The following is a description of a gene set: Mouse Gene Set: MIR_215_3P Genes predicted to be targets of miRBase v22 microRNA mmu_miR_215_3p in miRDB v6.0 with MirTarget v4 prediction scores > 80 (high confidence targets). studied in species Mus musculus from publication Chen Y, Wang X (PMID 31504780), and this is the list of marker genes: Map3k20, Tbl1xr1, Nsun5, Coro2b, Eif4enif1, Zfp689, Tmem45a2, Cxcl12, Ttc7b, Ikzf2, Slc9a2, Sdhd, Fdx1, Ccdc122, Hira, Srsf1, Ppig, Tnrc6b (trinucleotide repeat containing 6b), Slit2, Gna12, Ppargc1a, Rasl12, Slc26a3, Klhl4, Efcab5, Xk, Rundc3a, Sim1, Rgmb, Hdac9 (histone deacetylase 9), Tnn, C1galt1c1 (NCBI Gene Id 97604), Scai, Eif1a, Ankrd66, Ophn1, Ntrk2, Dcun1d1, Grid1, Clk2, Tead1, Ereg, Cul2, Sgcd, Rab38, Tenm3, Fli1 (Friend leukemia integration 1), Ftsj1, Spopfm2, Rfx3, Tmem45a, Tfrc, Ppp1r2, Htr4, Hsf3, Zmat2, Sfmbt1, Timm8b, Tmem65, Gpm6b, Hp1bp3, Tmem168, Pramel1 (PRAME like 1), Itgbl1, Eif4h, Ccin, Nrarp, Avl9, Yaf2, Nans, Lratd1, Nfib, Igsf11, Dmd, Zc3h14, Sertad2, Becn1, Sec23ip, Sulf1, Wwp1, Fbxo30, Spock3, Baz1b (bromodomain adjacent to zinc finger domain, 1B), 6030458C11Rik, Radil, Togaram1, Kcnh8, Atp2a1, Gpcpd1, Dnajb5, Trub1, Zfand4, Tom1l1, Lrtm1, Dclk1, Gdi2, Fam168a, Pcdh9, Pafah2, Cysltr1 (cysteinyl leukotriene receptor 1), Uty, Tbcel, Chsy3, Cnot6l, Gli2, Frrs1l, Dgkb, Meox2, Strn, Ckmt2, Sumf1, Zfp110, Usp15, Bpifc